The following is a description of a gene set: Human Gene Set: WP_MAJOR_RECEPTORS_TARGETED_BY_EPINEPHRINE_AND_NOREPINEPHRINE studied in species Homo sapiens Major receptors targeted by epinephrine and norepinephrine, and this is the list of marker genes: ADRA2C, ADCY1, ADRB1 (NCBI Gene Id 153), ADCY9 (NCBI Gene Id 115), ADRB2, ADCY3 (NCBI Gene Id 9608), ADRA2A, ADRA1D, ADCY5, ADCY10, ADRA2B, ADCY8, ADCY6, ADCY2, ADCY7, ADCY4